Given this list of marker genes PRKAR2A-AS1, ERCC6L2, LTV1, ASNS, VPS37C (NCBI Gene Id 55048), ELL3, TICAM1, ARHGAP11A, RPAP3, CHAF1A, SCAMP5, PRSS36, EMC1, TMED1, TSNAX-DISC1, MAPK14, APEX1, SMARCA5, FILIP1, ZNF585B, RDH10, FAM184A, RPL23AP82, PSMD1, RBM26, RPL17, LINC02028, GSTCD (NCBI Gene Id 79807), BUD31, SRMS, ANKFY1 (NCBI Gene Id 57500), STAM-DT, NR3C1, ACCS, DARS1, ARHGAP18, TSGA10, NUP205, VDAC2, GOSR2-DT, BIRC8, TMEM169, FNDC11, SRD5A1, DZANK1, MED1, LINC00347, WNT10A, HOMER2, STK36, AHSA1, TAF1D, AGA, CCNC, ENSG00000271860, PNO1, MATR3, ITM2A, GOSR2, ERRFI1-DT, TIPIN (NCBI Gene Id 54962), ANAPC7, DHRS7, CEP76, FNTA, INTS9, ZKSCAN2, RMI2, PTGES3, NDFIP2-AS1, MARCHF7, SPAG9, NOL11, IMP3, ARFGEF2, EIF3F, TBCK, C6orf52, ATR, SLC12A2-DT, MAPKAPK5, TMEM248, STYXL1, NSMF, SKAP1-AS2 (NCBI Gene Id 105371807), IMMP1LP1, VARS1, SIPA1L1, GUSBP1, PECR, RAD52, RNU12, TRAPPC2, RPS9, GORAB-AS1, AURKAIP1, INTS12, MIA2, RNA5SP205, ZRANB2, POP7, RELCH, ZNF821, SMAP2, INKA2, MIA2-AS1, DDHD1, HERC1, MAP3K7, DDX31, ALKBH5, LRRC40, OTUD4, PTGES2-AS1, MMS22L, NOP14, TMEM245, SHPRH, SUGP1, ACTR10, RNF14P3, PIK3CA, NANP, TAS1R1, RPS24, GAS6-AS1 (NCBI Gene Id 650669), PYGB, RPS10-NUDT3, SRSF7, RRAGA, CYP51A1-AS1 (NCBI Gene Id 613126), HEXIM1, TSNAX, SSR1 (NCBI Gene Id 6745), PRDX1, CRK, EXOC8, MED11, C20orf203, SLC15A4 (NCBI Gene Id 121260), HASPIN, RALBP1, RASSF7, HADHA, APBB3, WDR73, RPS12, ZNF687, LINC00661, COPB2, MED22, RPL10A, RPS11, PTGES2, ZNF668, ENSG00000267260, CFAP70, RPN1, TMEM209, HCG14, KIAA1191, MRPL57, RAB4B, FUBP1, ZNF582-DT, CDCA8, MAK16, SNX5 (NCBI Gene Id 27131), NCOA4, VMP1, MRPS7, C19orf48P, PURA, PKM, DMXL1-DT, HSPH1, CLHC1, MRPS5, ZFP91, PLEKHA2, MTG1, RAB33B, EDDM13, PPFIA3 (PTPRF interacting protein alpha 3), MT-CO1, DCAF16, PTRH2, CS, ZZZ3, MTAP, SMG5, SSR4, VDAC3, SHQ1, BAG6 (NCBI Gene Id 7917, BAG cochaperone 6), DHX37 (DEAH-box helicase 37), TTYH3, SMNDC1 (NCBI Gene Id 10285), TMCO1-AS1, ARHGAP11A-DT, SLC39A7, SLC3A2, SEC61B, HOMER1, FAM200B, PIK3CA-DT, MIR548H1, MCM5, BANK1, DNHD1, AJUBA, CIP2A, DNAAF10, SPRTN, HNRNPH3 (NCBI Gene Id 3189), MIR4539, FASTKD2, AMD1, RC3H2, CDH13-AS2, PRH1, PARP1, TMEM30A, ERCC6L2-AS1, TUBGCP5, SNX1, XPC, FAM53C, RPS6, MBTPS1, ADK, HS2ST1, USP3-AS1, REXO4 (NCBI Gene Id 90950), SLC35E3, SLMAP, PROSER1, RPAP3-DT, AKAP1-DT, VPS51, ACO2, CCT5, LRSAM1, RPL21, EDRF1-DT, PATL2, RPL7, YY1-DT, LYRM7, LINC02918, NDUFA11, RAD9A, SC5D, ZCWPW1 (zinc finger CW-type and PWWP domain containing 1, NCBI Gene Id 55063), ZNF219, APCDD1L, RPGRIP1L, TMEM79, CYB5D1, WDR41, PIPOX, CNPY2-AS1, FBXL5, LDC1P, STK33, IKZF5, AKAP11 (A-kinase anchoring protein 11), NUP85, SS18, PLEKHM1P1, DENR, LUC7L2, IQCG, LRR1, RPL12, LINC00511, ZNF687-AS1, HELQ, AKAP1, REXO1, RPL35A, LINC00635, LRRC41, NANOS3, PCBP1-AS1, RAB4B-EGLN2, SEH1L, NME6, TSPAN3, RPL7A, ACAD11, VOPP1, CREBZF, PFKFB2, FOXJ3, ZNF850, SNHG32, GPATCH3, PCBD2, HDGFL2, SELENOF, RASA1, STRIP1, YIPF3, SMC2, SLC39A13, CEP83-DT, SNAPC3, LRRC32, HCCS-DT, MTNAP1, HUWE1, NSUN3, NDUFA10, ATPSCKMT, ANKRD13C-DT, SUPT5H, PTPN4, METTL16, SSB, GSDMB, SNHG3, ANP32E, ZNF136, MEPCE, SYTL2, TERC, CAPRIN1, TMEM18, CENPT, AK6, CDC20, POLDIP3, ARHGAP11B-DT, PAK1IP1, KIF2C, RWDD1, TMEM277P, NCAPG, ZFP91-CNTF, SELL, LRRC28, AGBL3, C11orf54, MED21, GLB1, JOSD2, CHURC1, GORAB, LIN7C, SPATC1L, CLMAT3, IFT74, TIMM9P2, XPNPEP3, RXYLT1, ATF2, KLHL23, NCAPG2, PDE4A, KIAA1586 (KIAA1586), OSGEP, ITGA4, SEC62, EDRF1, SEPTIN7, DBR1, ATG2A, USP17L16P, TAB3, SLC35A4, BLCAP, ASXL1, PIN4, ZNF414 (NCBI Gene Id 84330), ZNF337-AS1, FAM76A, SIL1, RPS7, SEC14L1, RXRB, GSK3B-DT, THAP2, NAA35, MIR933, AP2B1, ARL5B, GRWD1, TGFB1, MT-TW, SMARCAL1 (NCBI Gene Id 50485), ALAS2, CD33, IL5, ASH2L, AOX1, ANKRD13C, RBM15, EIF4A2, GDPD5 (NCBI Gene Id 81544), ZNF335, DENND4C, CEP44, SNHG16, RPS15A, GGA3, RGS14, NDUFA7, SNORD2, SMG7-AS1, ESRP2, TAS2R14, CUL3 (NCBI Gene Id 8452), HSPA4, EPHB1, WDR77, MGRN1, FBXO8, TMEM237, HMGB3P22, ZNF646, SLC39A9, ZFC3H1, EXOSC5, SPDL1, IREB2, DPH6-DT (DPH6 divergent transcript), USP54, SEC11C, MALT1, NCLN, LYRM4 (LYR motif containing 4), LGI1, SEC63, ALG2, CHURC1-FNTB (CHURC1-FNTB readthrough), PLK5, DHFR2, ATP6AP1L, ABHD18, SNORD42B, PAXBP1, CKAP2-DT, STAG3L3, CANX, RSRC2, SNORD45C, EIF5, UPF3B, C6orf120, TMEM91, AIMP1, UBE2D3, ASB1, WDR6, COPB2-DT, FAM228B, SEPTIN7-DT, COX7B, COASY, NRSN2-AS1, JPX, NVL (NCBI Gene Id 4931), GRK4, MBTPS1-DT, PIGN, CHROMR, ISLR2, LGMN, PCBP1, GPBP1, COX7A2L, ERLEC1, HSPA9 (heat shock protein family A (Hsp70) member 9), MRPS14, RPL27A, MDFIC, CIT, NELFA, POLE, SNORD58B, ABRAXAS2, PMS1, AKAP3, AIRIM, POLR1C, STXBP4, DCTN2, IRGQ, C1orf74, RBBP5, NUDT2, PSMD12, TMCO1, GIPC2, DDHD2 (DDHD domain containing 2), DZIP3, NCOA3, UBE2D3-AS1, PI4KB, ATF7, PAF1, DMXL1, ASAP1, CCDC103, RBM17P4, ORMDL1, SRSF10, RAD50, LINC01348, KIN, RPL26 (NCBI Gene Id 6154), HSPA1B, LIPT1, ERGIC2, RN7SL220P, C6orf89, AXDND1, ICE1, VIPAS39, NWD2 (NCBI Gene Id 57495), TAOK1, COX11, DOHH, DNTTIP2, CCT4, CDC20-DT, RPS19, NSUN2, ZNF576, DDX39B, ARHGAP31, FARS2, RPL17-C18orf32, IFI27L2 (interferon alpha inducible protein 27 like 2), MAP2K2, EFHC1, COMMD1, MICOS10-DT, SRRT, ANAPC11, NCOA2, RNU7-49P, ZNF692, AFF4-DT, WNT3A, PDHX, ATP5PB, RNF167, FARSB (NCBI Gene Id 112957), MIR4507 (NCBI Gene Id 100616135), FRA10AC1, SF3B3 (NCBI Gene Id 9661), TBC1D17, POU5F1P7, CACTIN, KLC4, PRDM10, GAN, POLR3F, GADD45GIP1, GSK3B, IST1, SLC25A11, AARS1P1, MAD1L1, ETF1, IFRD1, IFT74-AS1, YOD1, PHF12, CDC5L, SYT9-AS1 (SYT9 antisense RNA 1), LINC00877, DYNC2I2, TMEM183A, SNORD101, SMG7, ZNF582, PSMG2 (proteasome assembly chaperone 2), ZNF566-AS1, EPCIP-AS1, FHL1P1, RABL2B, ZNF317, AHCTF1, FAM187A, WDR27, LSM6P2, NRSN2, LPIN2 (lipin 2), IDE, EIF4ENIF1 (NCBI Gene Id 56478), TTC8, ENSG00000187951, ERRFI1, RPL4, MTMR8, BZW1, SRSF11, MIR4538, AP3M1, VPS50, ZNF566, SAXO1, HSBP1, RNPC3, PLAC8, CALY, NDUFA4, OFD1, PSMD5, NOP16, MX1, TMEM30A-DT, DDX39B-AS1, ZNF383, ABI1, NFYC, RPS29 (ribosomal protein S29), PRKY, CAT, IPO13, STAT5A, LDLRAD4, ZRANB2-DT, NEUROG2-AS1, RBM26-AS1, RFC3, CDC73, E2F3P1, DPH6 (NCBI Gene Id 89978), SRCAP, UPF2, INTS8, RPS23, RBPJ, VAX1, PES1, SLBP, RBKS, ARF3, NDFIP2, RPL23A, METTL26, PROS1, ST13, NOL9, EFNB1, CNPY2, RABGGTB (Rab geranylgeranyltransferase subunit beta), BDNF-AS, RWDD2A, ATP6V0A1 (NCBI Gene Id 535), BTBD10, HECTD3, HMBOX1, MRPL9, QRICH1, DPF1, CCDC77, TSC22D2, CAND1, RAMAC, CIRBP, MRTO4, FSIP1, YY1, UHRF2, KIF20A, CKAP2, MYEF2, RBM39, XIST, SLC12A2, BCAS3 (NCBI Gene Id 89751), RPGRIP1, ALYREF, UFM1, GAS8, C19orf38, IL17F, NHLRC3, RNPC3-DT, SUPV3L1, GOLGA5, EIF4A3, FGFR1OP2, ADGRG1, DSE, PPP4R3B-DT, ZNF692-DT, NKRF, ETFA, FOXS1, ERICH6-AS1, SPATA4, PLA2G4F, ANAPC5 (NCBI Gene Id 51433), TOX2, MDH2, ZNF233, RPL36AP34, RPS27A, MRPS18C, PPFIBP2, CSMD2-AS1, FGFR3P5, SELENOH, PPP4R3B, SKP1, LMAN2, MICOS10-NBL1, OAZ3, MT-TQ, ZNF286A-TBC1D26, CDK12, PRR4, MED29, ACADSB, AGPAT3, MGME1, CHD8, ADNP, PDAP1, ZNF286A, CPLX1, MICOS10, MCRIP2, TSN, MAU2, PUF60 (NCBI Gene Id 22827), SSX2IP, TSPYL1, ENSG00000233461, GMPPA, IDH3G, OR5F1, ATP5MG, EPB41L3, LMNTD2, SPAG8, RPS10, LPXN, GOLM2, PGM3, EIF2S3, PDIK1L, TMEM147-AS1, THAP1, MYCBP2, DDHD1-DT, EFTUD2, MPC2 (mitochondrial pyruvate carrier 2), SKA3, RNF25, PFN4, DCTN1, WDR70, C3orf86P, DCAF1, NAA38, KPNA2, DNAJB4, UIMC1, STT3B, SLC35B1, RAD17, RABL2A, SLFN13, BABAM2, TBL1X, STAM2, PHF5A, UPF3A, PXMP2, BCKDHA, GATAD2B, VCF1, SNORD48, NSUN6, ARSA, CMTR1, UROD, ITGAE, MDH1B, SUCLG1, INTS13, HCCS, CCDC97, SPAG16, SART3, RBM6, SLU7, MIR6835, ATP5F1C, VTI1B, HADHB, SUDS3, ERICH6, KCNJ14, ZNF397, POLR2E, CEP83, HYLS1, ZNF346, GTPBP8, COQ9, HSPA8, SRRM5, FCHSD1, ATP6V1C2, ZWILCH, PPCDC, ATF7-NPFF, SRP19 (signal recognition particle 19), IRAG2, RNA5SP101, SPAG16-DT, BRME1, TTC23, FTO, APIP, TM9SF1, TMPPE, LSM8, COG4, RAB33B-AS1, TAF9, MAPKAPK5-AS1 (MAPKAPK5 antisense RNA 1), STAM, MFSD8, CIAPIN1, CDKL3, RPS28, GRPEL1, MRPL11, ERH, RCC1, BANP, NDC1, RFC5, RPL23AP7, DCAF6, NPC1, RNA5SP20, MYO9A (myosin IXA), here is a description of the gene set: species: Homo sapiens Genes containing one or more binding sites for (IRF5) in their promoter regions (TSS -1000,+100 bp) as identified by GTRD version 20.06 ChIP-seq harmonization. Human Gene Set: IRF5_TARGET_GENES from publication Yevshin I, Sharipov R, Kolmykov S, Kondrakhin Y, Kolpakov F (PMID 30445619)